The following is a description of a gene set: Complement system in neuronal development and plasticity species: Homo sapiens Human Gene Set: WP_COMPLEMENT_SYSTEM_IN_NEURONAL_DEVELOPMENT_AND_PLASTICITY, and this is the list of marker genes: FAS, C1QB, C2, CFP, XIAP, FCN1, MFGE8, PALS1, CR2, DLGAP5 (DLG associated protein 5), ATP8B2, VTN, CASP10, CRB1, FASLG, MASP2, ATP11C, PLSCR1, SERPING1, ITGB2, PLSCR3, BAX, BID, CFD, ITGAV, CLU, MARK1, TGFB2, CR1, CD55, SUSD4, TGFB3, MARK3, PRKCZ, LLGL2, PARD6B, CX3CL1, PLSCR4, C1S, CFH, CYCS (cytochrome c, somatic), PROS1, C7, CX3CR1 (C-X3-C motif chemokine receptor 1), FCN2, AXL, PRKCI, C1R, PARD6G, MASP1, ITGB3, PARD6A, COLEC11, CD46, MARK2, C4B, MBL1P, SCRIB, CFI, CSMD1, CASP9, C5AR2, CASP8, FCN3, APAF1, HTRA2, ITGAM, CASP3, PATJ, C4A, COLEC10, C5, ITGAX (NCBI Gene Id 3687), C3, ATP8B1, MBP, TYRO3, C6, DIABLO, C8A, C4BPB (complement component 4 binding protein beta), PARD3, C3AR1, CFB, TGFB1, BAK1, MERTK, C1QA, C1QC, GAS6, DEDD, ATP10A, COLEC12, CRB2, C9, C4BPA, MBL2, C5AR1, CD59, ATP11A, C8G, CAP1, ATP8B3, C8B, IFNG, CASP7